Given this list of marker genes HPRT1P3 (hypoxanthine phosphoribosyltransferase 1 pseudogene 3), RNA5SP345, DEUP1, SNORA1, SMCO4, VSTM5, RNA5SP346, ARPC3P3, SNORA8, BUD13P1, MIR548L, KDM4D, C11orf54, LINC02553, HEPHL1, PANX1, RPL32P25, SNORA32, TAF1D, ENDOD1, CCDC82, MIR1260B, SCARNA9, MIR1304, ANKRD49, SRSF8, AMOTL1, SNORA25, FUT4, SNORD6, SESN3 (sestrin 3), SLC36A4, AKTIPP3, LNCRNA-IUR, CWC15, SRP14P2, SNORA18, FAM76B, MTMR2, KDM4F, ST13P11, RN7SL223P, C11orf97, PIWIL4, CEP57, LINC02700, JRKL-AS1, ENSG00000255605, LINC02737, IZUMO1R, SNORD5, PIWIL4-AS1, MED28P5, JRKL, KDM4E, MED17 (mediator complex subunit 17), MRE11, PHB1P16, CEP295, GPR83, RPL26P31 (NCBI Gene Id 100271469), MAML2, SNORA40, SRSF8BP, here is a description of the gene set: studied in species Homo sapiens Human Gene Set: chr11q21